Given this list of marker genes TYMP, UPP2, UCKL1, DTYMK, TK2, ERH, NT5C3A, CDA (NCBI Gene Id 978), DPYD, DCTD, APOBEC3C (NCBI Gene Id 91578), CDADC1, APOBEC3G, AICDA, UPB1, DHFR2, TK1, UPP1, here is a description of the gene set: studied in species Homo sapiens The chemical reactions and pathways involving any pyrimidine nucleoside, one of a family of organic molecules consisting of a pyrimidine base covalently bonded to ribose (a ribonucleoside) or deoxyribose (a deoxyribonucleoside). Human Gene Set: GOBP_PYRIMIDINE_NUCLEOSIDE_METABOLIC_PROCESS